Given this list of marker genes PSTPIP2, NR2F1, TOX, FN1, PTHLH, ID4, JAG1, here is a description of the gene set: Genes up-regulated in SaOS-2 cells (osteosarcoma) upon expression of PAX3-FOXO1 but down-regulated by PAX3 expression off adenoviral vectors. from publication Begum S, Emami N, Cheung A, Wilkins O, Der S, Hamel PA (PMID 15688035) The oncogenic fusion protein, Pax3/FKHR, is a more potent transcription factor relative to its normal counterpart, Pax3. Since Pax3 induced a mesenchymal to epithelial transition (MET) in human SaOS-2 osteosarcomas, we hypothesized that Pax3/FKHR would also induce a morphological change in SaOS-2 cells. We demonstrate here that Pax3/FKHR more potently induces a MET in SaOS-2 cells than Pax3. This greater potency was further evident where Pax3/FKHR, but not Pax3, induced a morphological alteration in U2-OS osteosarcoma cells. By microarray analysis, we determined that Pax3/FKHR altered the expression of gene targets in a manner quantitatively and qualitatively distinct from Pax3. Three classes of genes were identified: (i) genes induced or repressed by Pax3 and Pax3/FKHR, (ii) genes induced or repressed by Pax3/FKHR but not Pax3 and (iii) genes induced by Pax3/FKHR but repressed by Pax3. Chromatin immunoprecipitations confirmed the direct binding of Pax3/FKHR to the promoter region of several factors including cannabinoid receptor-1, EPHA2 and EPHA4. Verification of the microarray data also revealed coordinate alteration in the expression of factors involved in BMP4 signalling. Regulation of gene expression by Pax3 and Pax3/FKHR is, however, cell-type specific. BMP4 expression, for example, was repressed by both Pax3 and Pax3/FKHR in SaOS-2 cells, while in the rhabdomyosarcoma, RD, Pax3/FKHR, but not Pax3, induced BMP4 expression. Thus, our data reveal that Pax3/FKHR regulates a distinct but overlapping set of genes relative to Pax3 and that the global set of Pax3 and Pax3/FKHR gene targets is cell-type specific. species: Homo sapiens Human Gene Set: BEGUM_TARGETS_OF_PAX3_FOXO1_FUSION_AND_PAX3